The following is a description of a gene set: studied in species Mus musculus An assembly of four or five subunits which form a structure with an extracellular N-terminus and a large loop that together form the ligand binding domain. The C-terminus is intracellular. The ionotropic glutamate receptor complex itself acts as a ligand gated ion channel; on binding glutamate, charged ions pass through a channel in the center of the receptor complex. Kainate receptors are multimeric assemblies of GluK1-3 (also called GluR5-7), GluK4 (KA1) and GluK5 (KA2) subunits. Mouse Gene Set: GOCC_KAINATE_SELECTIVE_GLUTAMATE_RECEPTOR_COMPLEX, and this is the list of marker genes: Grik3, Grik5, Grik4, Grik1, Gria4, Grik2